The following is a description of a gene set: Reactome Pathway: Amine Oxidase reactions part of: Phase I - Functionalization of compounds Human amine oxidases (AO) catalyze the oxidative deamination of biogenic amines (neurotransmitters such as serotonin, noradrenaline, the hormone adrenaline and polyamines such as the spermines) and xenobiotic amines (exogenous dietary tyramine and phenylethylamine). The basic reaction is the oxidative cleavage of the alpha-H to form an imine product with the concomitant reduction of a FAD cofactor. The imine product then hydrolyses to an aldehyde and ammonia (or amine for secondary and tertiary amine substrates). Reduced FAD is reoxidized to form hydrogen peroxide to complete the catalytic cycle.<p>The reaction can be summarized as</p><p><b>RCH2NH2 + H2O + O2 = RCHO + NH3 + H2O2</b></p><p>The resultant hydrogen peroxide is the source of the most toxic free radical, the hydroxyl radical (.OH). This free radical is produced in the Fenton reaction with the use of ferrous (Fe2+) iron.</p> studied in species Homo sapiens, and this is the list of marker genes: MAOB, MAOA, PAOX, SMOX